Given this list of marker genes Mus81, Brca2, Gen1, Firrm, Brca1, Rad51ap1, Bard1, Slx1b, Slx4, Rad51c, Kat5, Palb2, Xrcc3, Wrn, Top3a, Rad51b, Rbbp8, Dna2, Mre11a, Fignl1, Blm, Nbn, here is a description of the gene set: studied in species Mus musculus electronically inferred by orthology from the curated human pathway Reactome Pathway: Resolution of D-Loop Structures part of: HDR through Homologous Recombination (HRR) This event has been computationally inferred from an event that has been demonstrated in another species.<p>The inference is based on the homology mapping from PANTHER. Briefly, reactions for which all involved PhysicalEntities (in input, output and catalyst) have a mapped orthologue/paralogue (for complexes at least 75% of components must have a mapping) are inferred to the other species.